Given this list of marker genes Dio3, Per2, E2f1, Fto, Trem2, Fgf10, Vstm2a, Sqstm1, Pid1, E2f3, Tfdp1, Il4, Ceacam2, Col6a1, Atf2, Lipa, Ppard, Fgf16, here is a description of the gene set: species: Mus musculus The multiplication or reproduction of fat cells by cell division, resulting in the expansion of their population. A fat cell is an animal connective tissue cell specialized for the synthesis and storage of fat. Mouse Gene Set: GOBP_FAT_CELL_PROLIFERATION